Given this list of marker genes KCNMA1, ANKRD11, DHX37, CDK10 (cyclin dependent kinase 10), GRIA3, VPS13B, MBD5, VPS51, IRF6, SMOC1, PURA, PACS2, BRD4, PQBP1, FARS2 (phenylalanyl-tRNA synthetase 2, mitochondrial), TBC1D24, BRF1, TP63, KCNK9, ABCC9, CTCF, MAPK8IP3, NECTIN1, ASCC3, BRCA1, MGAT2, GJA1, ATP6V1B2, MSX1, CACNA1I, COL11A1, here is a description of the gene set: species: Homo sapiens Macrodontia Increased size of the teeth, which can be defined as a mesiodistal tooth diameter (width) more than 2 SD above mean for age. Alternatively, an apparently increased maximum width of the tooth. Human Gene Set: HP_MACRODONTIA